Given this list of marker genes CKS1B, CENPF, NDC80, TOP2A, RRM1, BUB1, HMMR, MCM3, NUSAP1, PRIM1 (NCBI Gene Id 5557), FOXM1, MCM6, CDK1, SMC4, ASPM, BIRC5, MT1JP, KIF11, CCNB2, CCNA2, CDC20, SMC2, RFC3, ZWINT (NCBI Gene Id 11130), CENPE, RFC4, ESPL1, PCNA, CDCA8, KIF18B, TTK, CKS2 (NCBI Gene Id 1164), MYBL2, here is a description of the gene set: Human Gene Set: GNF2_SMC2L1 species: Homo sapiens Neighborhood of SMC2L1 Neighborhood of SMC2L1 NULL in the GNF2 expression compendium